Given this list of marker genes CNGA1, PDE6A, PDE6G, CNGB1, RHO, GNB1, GNAT1, PDE6B, SLC24A1, SAG, GNGT1, here is a description of the gene set: part of: The phototransduction cascade The photoreceptor cascade starts with light isomerization of 11-cis-retinal (11cRAL) of rhodopsin (RHO) to all-trans-retinal (atRAL), inducing a conformational change in RHO to the active, metarhodopsin II (MII) state. MII activates the G protein transducin (Gt) that in turn activates phosphodiesterase 6 (PDE6). Consequently, there is a fall in the intracellular concentration of cGMP that closes cGMP-dependent cation channels (CNG channels) and hyperpolarizes the rod. This has the effect of reducing or stopping glutamate release from synaptic vesicles thus signalling to the surrounding cells how many photons were absorbed (Burns & Pugh 2010, Korenbrot 2012, Pugh & Lamb 1993). Reactome Pathway: Activation of the phototransduction cascade species: Homo sapiens